The following is a description of a gene set: species: Mus musculus Mouse Gene Set: GOBP_REGULATION_OF_WOUND_HEALING Any process that modulates the rate, frequency, or extent of the series of events that restore integrity to a damaged tissue, following an injury., and this is the list of marker genes: Klkb1, Actg1, Vtn, St3gal4, Xbp1, Ephb2, Psg23, Serpinc1, Sh2b3, Apoh, Ccl2, Eppk1, Pros1, C1qtnf1, Cd36, Hrg, Foxc2, Cldn1, Foxa2, Cask, Clec7a, Plau, Ubash3b (NCBI Gene Id 72828), Cav1, Clasp2, Tmprss6, Serpine1, Cxcr4, Plg, Cldn13, Anxa5, Fgg, Tnf, Kng1, S100a9, Clasp1, Ano6, Prkcd, Adtrp, Cldn3, Gp5, Serpine2, Cldn19, Thbs1, Adra2a, Fermt1, Prkce, Slc12a2, Ptger4, Serpinf2 (NCBI Gene Id 18816), Ajap1, Tpsab1, Prdx2, F7, Cd9, Alox5, Insl3, Plaur (plasminogen activator, urokinase receptor), Tnfrsf12a, Wfdc1, F12, F2rl1, Enpp4, Phldb2, Fgb, Emilin1, Anxa2, Tafa5, Hif1a, Serping1, Plat, Hbegf, Adamts18, Arfgef1, Itgb1, Kng2, Pdgfra, Ddr2, Apoe, F11, Alox12, Srsf6, Mtor, Duox1, Tspan8, Kank1, F2, Fermt2, Cldn4, Vwf, Vegfb, Tmx1, Myoz1, Pdgfb, Tmem97, Rreb1, Pdgfa, Dmtn, Mylk, Hras, Smad3, Smoc2 (NCBI Gene Id 80628), Mmrn1, Hmgb1, Prkg1, Emilin2, Ceacam1, Cadm4, Thbd, F2r, Nfe2l2, Tbxa2r, Cd109, Ptk2, Fga, Cpb2, Pten, Muc16, Gp1ba, Reg3g, Vkorc1, Duox2, Crk, Fgf2, Hpse, Vil1, Anxa1, Tfpi, Wnt4 (NCBI Gene Id 22417), Reg3a, Ccn4, Proc